The following is a description of a gene set: species: Homo sapiens To assess gene signatures related to humoral response among healthy older subjects following seasonal influenza vaccination, we studied 94 healthy adults (50-74 years old) who received one documented dose of licensed trivalent influenza vaccine containing the A/California/7/2009 (H1N1)-like virus strain. Influenza-specific antibody (HAI) titer in serum samples and next-generation sequencing on PBMCs were performed using blood samples collected prior to (Day 0) and at two timepoints after (Days 3 and 28) vaccination. We identified a number of uncharacterized genes (ZNF300, NUP1333, KLK1 and others) and confirmed previous studies demonstrating specific genes/genesets that are important mediators of host immune responses and that displayed associations with antibody response to influenza A/H1N1 vaccine. These included interferon-regulatory transcription factors (IRF1/IRF2/IRF6/IRF7/IRF9), chemokine/chemokine receptors (CCR5/CCR9/CCL5), cytokine/cytokine receptors (IFNG/IL10RA/TNFRSF1A), protein kinases (MAP2K4/MAPK3), growth factor receptor (TGFBR1). The identification of gene signatures associated with antibody response represents an early stage in the science for which further research is needed. Such research may assist in the design of better vaccines to facilitate improved defenses against new influenza virus strains, as well as better understanding the genetic drivers of immune responses. Human Gene Set: OVSYANNIKOVA_PBMC_FLUARIX_AGE_55_64YO_RESPONDERS_VS_NONRESPONDERS_28DY_DN from publication Ovsyannikova IG, Oberg AL, Kennedy RB, Zimmermann MT, Haralambieva IH, Goergen KM, Grill DE, Poland GA (PMID 27441275) Genes down-regulated in peripheral blood mononuclear cell responders vs nonresponders in adults (55-64) after exposure to Fluarix, time point 28D. Comment: Gene expression related to HAI response, and this is the list of marker genes: SLC38A9, NCKIPSD, TMEM104, AP1M2, PEF1, B3GNTL1, LIAT1